The following is a description of a gene set: species: Homo sapiens Generation of second messenger molecules Human Gene Set: REACTOME_GENERATION_OF_SECOND_MESSENGER_MOLECULES, and this is the list of marker genes: ITK, HLA-DRA, NCK1, HLA-DRB5, LAT, CD3G (CD3 gamma subunit of T-cell receptor complex), PAK1 (NCBI Gene Id 5058), FYB1, HLA-DPB1, PAK2, HLA-DRB3, TRAV8-4, ZAP70, WAS, PAK3, TRBV7-9, LCP2, ENAH, CD3D, HLA-DQA1, HLA-DQB1, LCK, HLA-DQB2, CD4, PLCG1, HLA-DQA2, TRBV12-3, EVL, PLCG2, HLA-DRB1, CD3E, CD101, VASP, TRAV29DV5, CD247, HLA-DPA1, HLA-DRB4, TRAV19 (T cell receptor alpha variable 19), GRAP2